The following is a description of a gene set: Signaling by Nuclear Receptors species: Mus musculus Mouse Gene Set: REACTOME_SIGNALING_BY_NUCLEAR_RECEPTORS, and this is the list of marker genes: H3c1, Pdha2, Gtf2a1, Sdr16c5, Rara, Polr2b, Cdkn1b, H2bc12, Egf, H3c3, Gng4, Pdk3, H4c17 (H4 clustered histone 17), H2bc7, Pik3r2, Rdh10, H2bc11, Greb1, Xpo1, Pdhb, Shc1 (src homology 2 domain-containing transforming protein C1), Akt1, H2bc24, Areg, Hbegf, Gnb3, Gnai2, Akr1c6, Gng5, Polr2c (polymerase (RNA) II (DNA directed) polypeptide C), H3c6, H2bc9, Pik3r1, Pdk2, Pik3r3, H2bc3, Pdha1, Ptges3, Gng7, H4c6, H4c16, Rxrb, Kat5, H4c3, H4c4, Nrip1, Ep300, H4c8, Tbp, Gng2, Aldh1a3, H3f3a, Ptk2, Usf1, H4c11, Prkcz, Foxo3, H4c2, Ccnt1, H3c15, Prmt1, H2aj, H3c8, H2bc15, Mmp3, Gata3, Esr2, H3f3b, Ncor2, Gng3, Gngt2, Epgn, Cyp26b1, Erbb4, Dhrs3, Rdh5, Tle3, Calm2, Dld, H4c14, Polr2h, H3c10, Cdk9, Dlat, Src, H2bc23, Rdh1, H2bc13, Gng11, Crabp1, Cbfb, Rxra, Gps2, Foxa1, Sp1, H3c4, Gng10, Rarg, Fkbp4, Polr2f, Cited1, Rdh11, H2bc1, Polr2g, Kdm1a, Sphk1, Mapk1, Rxrg, Strn, Gng8, Pik3ca, Abca1, Cav1, Polr2i, Cyp26c1, Mmp9, Egfr, Dhrs9, Gnb1, Ereg, Kras, Rdh13, Aldh1a2, Gnat3, Hsp90ab1, Akt2, Nr1h2, Akr1c20, Nos3, H2bc22, H3c13, Gnai1, Akr1c21, Polr2l, Akt3, H4c18, Cyp26a1, H4c9, Aldh1a1, Tbl1xr1, Calm3, H2bc8, Polr2d, Hras, H2bc21, H2bc26, Ppard, Aldh8a1, Kat2b, Nr1h3, Crabp2, Gtf2f1, Rdh14, Dhrs4, H2bc4, Gng13, Rarb, Hdac3, Usf2, H4c12 (H4 clustered histone 12), Esr1, Cav2, Ppp5c, Btc, Pdhx, Mmp7, Carm1, Fkbp5, Hspb1, Polr2k, Calm1, Pdk1, Fabp5, H4c1, Pdpk1, Gnb4, Tgfa, Hsp90aa1 (NCBI Gene Id 15524), Igf1r, Tbl1x, H2bc14, Gnb5, Zdhhc21, Adh1, H3c11, Gtf2f2, Polr2a, Gng12 (guanine nucleotide binding protein (G protein), gamma 12), Gtf2a2, Ddx5, Polr2e, Med1, Pgr, Ncoa2, Uhmk1 (U2AF homology motif (UHM) kinase 1), H3c7, S1pr3, H3c14, Gngt1, Zdhhc7, Adh4, Pdk4, Gnb2, H2bc6, Creb1, Gnai3, H3c2, Mmp2, Ncoa1 (nuclear receptor coactivator 1)